Given this list of marker genes CTNNA2, ATP1B2, LEF1, ITGB1, FLNA, ARL13B, RERE, CEND1, DAB1 (NCBI Gene Id 1600), here is a description of the gene set: The radially directed movement of a cell along radial glial cells in the hindbrain. Radial migration refers to a directed movement from the internal ventricular area to the outer surface of the hindbrain. Human Gene Set: GOBP_HINDBRAIN_RADIAL_GLIA_GUIDED_CELL_MIGRATION studied in species Homo sapiens